Given this list of marker genes Bcas1, Lrrc8d, Ap1s3, Crkl, Ppargc1a, Sash1, Spryd7, Dvl3, Nanos1, Eif5 (eukaryotic translation initiation factor 5), Apol11b, Hoxc8, Zfhx4, Arx, Esr1, Pts, Rictor, Gxylt2, Pcdh12, Pgpep1l, Dnaaf9, Mmrn1, Rgs12 (NCBI Gene Id 77052), Tnrc6b, Mmp13, Brd3, Ebf2, Inpp4a, Dcun1d3, Dmtf1, Ccdc120, Arap2, Mrps33, Nkx6-3, Wdr46, Zcchc24, Elf2, Jarid2, Amot, Tet1, Nrg3, Elavl3, Tgfbrap1 (transforming growth factor, beta receptor associated protein 1), Plekhm3, Siae, Gpm6a, Naa15, Poli, Ephb6, 2310002L09Rik, Ap2a2, Ranbp6, Rbm41, Ccdc68, Cd2ap, Hnrnpa2b1, Birc6, Mmgt1, Insc (NCBI Gene Id 70692), Szrd1, Shc1 (src homology 2 domain-containing transforming protein C1), Vgll3, Fhip1b, Lsm5 (LSM5 homolog, U6 small nuclear RNA and mRNA degradation associated), Ccdc117, Npas3, Sgip1 (NCBI Gene Id 73094), Mlxip, Tppp, Ap3m1, Pcgf3, Sirt1, Nr3c1, Stk17b, Sos1, G2e3 (NCBI Gene Id 320853), Tmem164 (NCBI Gene Id 209497), Ogdh, Tmem263, Lnpep, Pum2, Arl8b, Mapk4, Slc16a4, Ankrd13a, Acer2, Nrarp, Tent5a, Mmab, Zranb3, Lgals3, Foxc1, Rhot1, Alcam, Rell1, Rtkn2, Dhh, Glis3, Hcn1, Prrx1, Spop, Abraxas2, Pdp1, Pfkfb2, Gcnt1, Aoah, Lrrn4cl, H2-M2, Hook3, Zfp521, Arhgap11a, Lhfpl4, Nuak1, Rnf170, Dnajc14, Nr3c2, Rreb1, Crat, Smim13, Lin7a, Lhfpl6, Slc38a9, Zfp629, Angpt1, Adamts5, Wee1, Tox3, Hapstr1, Dpy19l4, Dpp10, Gpbp1l1, Mapre2, Sec24d, Dennd1b, Ssrp1, Zfp423, Dera, Rps6ka5, Xrn1, Rab22a (NCBI Gene Id 99403), Mgat3, Itpr1, Igf2r, Zbed6, Dnm2, Pdcd10, Dppa2 (developmental pluripotency associated 2), Camk1, Ap1s2 (adaptor-related protein complex 1, sigma 2 subunit), Pid1, Epha7, Has2, Grm1, Ism1, Gcnt2, Ypel2, Atf2, Clmp, Nbea, Ncoa7, Napg, Atp2b1, Zfp36l1, Rims2, Spta1, Tsr1, Slc39a11, Fnip1, Onecut2, Slc49a4, Pex5l, Uba6, Iigp1, Gpatch11, Creb1, Hycc1, Dnajc13, Khdrbs1, Lypd6b, Plxna2, Hapln1, Larp4b, Samd5, Efnb3, Nova1, Acsl4, Zfp11, Dyrk1a (dual-specificity tyrosine phosphorylation regulated kinase 1a), Synj2, Ddr2, Epha4, Snx13, Ociad2, Fry (NCBI Gene Id 436454), Mbnl1, Tcf12, Ski, Smc2, Fam149a, Atf6, Ucp1, Dlg1, Dtwd1, Kmt5a, Rhobtb3, Pde1c, Frs2, Tanc2, Ezr, Evc2, Ccnt2, Ankfy1, Ago1, Ptprd, Dpf1, Gba1, Tomm70a, Slc39a9, Fbn2, Rere, Vax2, Tfap2a, Trim12c, Mcoln1, Spred1, Trp53inp1, Ppm1k, Cdh4, Fbxw7, Epha5, Esrrg, St7, Cpne8, Chp1, Slc43a1, Tnfaip8, Nin, Nrbf2, Cd74, Zfp282, Rragc, Tmc2, Trim36, Crtac1, Alpl, Hyal4, Grk4, Myo10, Cox5a, Eef1e1, P2rx7, Nfatc3, Rnf122, Pde12, Abcb10, A630023A22Rik, Ttyh1, Micu3, Fras1, Plcb1, Sf3b1, Cyp2j12, Sox11, Ssr3, Efemp2, Coro1c, Dync2i1, Ssh2, Zbtb7c, Lamp1, Ntrk2, Rnf138, Tgfbr2, Nbr1, Creb5, Slc16a6, Chn2, Arid3b, Zfhx3, Farp1, Lrp2, Pabpc6, Epdr1, Pusl1, here is a description of the gene set: Mouse Gene Set: MIR_204_5P from publication Chen Y, Wang X (PMID 31504780) studied in species Mus musculus Genes predicted to be targets of miRBase v22 microRNA mmu_miR_204_5p in miRDB v6.0 with MirTarget v4 prediction scores > 80 (high confidence targets).